Given this list of marker genes CAPRIN1, SLC25A23, PTPRB, PTPRR, TNFRSF10A, ACOT2, TACR3, KALRN (NCBI Gene Id 8997), WFDC11, RFXAP (regulatory factor X associated protein), MTA3, YAF2, RB1CC1 (RB1 inducible coiled-coil 1), CDH2, OAF, KRT10, TBP, MAST4, ESPN, RRAGC, NOVA1, ANKHD1, PDSS1, BMP6, ROCK2, SMC4, FAM20B, CORO2A, MC5R, CD8B, ZC3H12C, DOCK4, EVPLL, FAT4, TPK1, ZNF780A, RAPGEF5, ZNF644, NR2C2, ZBTB20, CIAPIN1, BTBD10, VRK3, RPS6KA4, VIM, MIB1, TMEM168, IL6R, PGAM4, ACVR2B, CCNDBP1, NHLRC2, OTUD1, H2AZ2, PARP8, STIM2, KLF12, BCCIP, ADAMTS3, RNF19B, FAM81A, CDK17 (NCBI Gene Id 5128), PRTG (protogenin), HSD11B1, QKI (QKI, KH domain containing RNA binding), CHMP2B, BEND6, ZFP91, MRGPRX2, ARID2, CHCHD4, ABHD17B, RBM3, GPHN, CCDC57, ARHGAP21, WNK1, DNM3, SGK2, FCGR2A, B4GALT1, UBAC2, PTPN4, ZNF224 (NCBI Gene Id 7767), LMO7 (LIM domain 7), REG4, TAT, CHD9, RDH11, PABPC4L, PSMA6, CADM2, FERMT2, MCTP2, IMP4, PRUNE2, CALN1 (calneuron 1), TMEM117, ZNF562, here is a description of the gene set: from publication Chen Y, Wang X (PMID 31504780) Genes predicted to be targets of miRBase v22 microRNA hsa-miR-4490 in miRDB v6.0 with MirTarget v4 prediction scores > 80 (high confidence targets). Human Gene Set: MIR4490 studied in species Homo sapiens